The following is a description of a gene set: The gene expression program underlying the specification of human cell types is of fundamental interest. The study authors generated human cell atlases of gene expression and chromatin accessibility in fetal tissues. For gene expression, the study authors applied three-level combinatorial indexing to >110 samples representing 15 organs, ultimately profiling ~4 million single cells. The study authors leveraged the literature and other atlases to identify and annotate hundreds of cell types and subtypes, both within and across tissues. Our analyses focused on organ-specific specializations of broadly distributed cell types (such as blood, endothelial, and epithelial), sites of fetal erythropoiesis (which notably included the adrenal gland), and integration with mouse developmental atlases (such as conserved specification of blood cells). These data represent a rich resource for the exploration of in vivo human gene expression in diverse tissues and cell types. Marker genes curated from the annotated cluster as represented in the Descartes Human Gene Expression During Development database. species: Homo sapiens Human Gene Set: DESCARTES_MAIN_FETAL_URETERIC_BUD_CELLS from publication Cao J, O'Day DR, Pliner HA, Kingsley PD, Deng M, Daza RM, Zager MA, Aldinger KA, Blecher-Gonen R, Zhang F, Spielmann M, Palis J, Doherty D, Steemers FJ, Glass IA, Trapnell C, Shendure J (PMID 33184181), and this is the list of marker genes: AQP2, ASTL, PVALB, LINC02944, MTCO1P12, MTND4LP30, KCP, GPR15LG, PLA2G2F, ENSG00000259039, ACER2, UPK1A, SCNN1G, DCAF12L1, EMX2, TBC1D9, ENSG00000250781, NUDT16-DT, ENSG00000258471 (NCBI Gene Id 101929718), HOXB7, LINC02778, CLPSL1, MYO3B, SPMIP4, MYEOV, RPL10P19, WNT9B, SHROOM1, NAALADL2, PTGR1, DHRS2, SNX31, MTND3P19, ELF5, SCNN1B, UPK2, ENSG00000266988, EMX2OS, UPK3A, NIPAL4, SLC14A2, MYO6, SEPTIN9-DT